The following is a description of a gene set: studied in species Mus musculus Reactome Pathway: Antigen Presentation: Folding, assembly and peptide loading of class I MHC electronically inferred by orthology from the curated human pathway This event has been computationally inferred from an event that has been demonstrated in another species.<p>The inference is based on the homology mapping from PANTHER. Briefly, reactions for which all involved PhysicalEntities (in input, output and catalyst) have a mapped orthologue/paralogue (for complexes at least 75% of components must have a mapping) are inferred to the other species. part of: Class I MHC mediated antigen processing & presentation, and this is the list of marker genes: Sec24d, Calr, B2m, H2-Q10, H2-M3, Tap2, Tap1, H2-M10.1, Sec24b, Erap1, H2-M10.2, Sec31a, H2-M2, H2-Q7, H2-M10.6, Sec24a, Bcap31, H2-M9